Given this list of marker genes Wdr89, Cxcr6, Psmc3, Emg1, Ramp1, Tmem176a, Tmem176b, here is a description of the gene set: from publication Tabula Muris Consortium (PMID 32669714) species: Mus musculus Mouse Gene Set: TABULA_MURIS_SENIS_LUNG_T_CELL_AGEING